The following is a description of a gene set: studied in species Homo sapiens A reduced sense of touch (tactile sensation) on the skin of the distal limbs. This is usually tested with a wisp of cotton or a fine camel's hair brush, by asking patients to say 'now' each time they feel the stimulus. Impaired distal tactile sensation Human Gene Set: HP_IMPAIRED_DISTAL_TACTILE_SENSATION, and this is the list of marker genes: VCP, RAB7A, ATL1, BSCL2, SETX, SPTLC2, HARS1, ADA2, DCAF8, MPV17, MTRFR, DHH, MORC2, NDRG1, POLG, TWNK, SPTLC1, ATL3, GDAP1, ATXN1, PNPT1, KLHL9